The following is a description of a gene set: species: Homo sapiens Mutation or epigenetic silencing of mismatch repair genes, such as MLH1 and MSH2, results in microsatellite instability (MSI) in the genome of a subset of colorectal carcinomas (CRCs). However, little is yet known of genes that directly contribute to tumor formation in such cancers. To characterize MSI-dependent changes in gene expression, we have now compared transcriptomes between fresh CRC specimens positive or negative for MSI (n=10 for each) with the use of high-density oligonucleotide microarrays harboring >44,000 probe sets. Correspondence analysis of the expression patterns of isolated MSI-associated genes revealed that the transcriptome of MSI+ CRCs is clearly distinct from that of MSI- CRCs. Such MSI-associated genes included that for AXIN2, an important component of the WNT signaling pathway. AXIN2 was silenced, apparently as a result of extensive methylation of its promoter region, specifically in MSI+ CRC specimens. Forced expression of AXIN2, either by treatment with 5'-azacytidine or by transfection with AXIN2 cDNA, resulted in rapid cell death in an MSI+ CRC cell line. These data indicate that epigenetic silencing of AXIN2 is specifically associated with carcinogenesis in MSI+ CRCs. Genes down-regulated in colorectal carcinoma samples positive for MSI (microsatellite instability) compared to the MSI negative ones. Human Gene Set: KOINUMA_COLON_CANCER_MSI_DN from publication Koinuma K, Yamashita Y, Liu W, Hatanaka H, Kurashina K, Wada T, Takada S, Kaneda R, Choi YL, Fujiwara SI, Miyakura Y, Nagai H, Mano H (PMID 16247484), and this is the list of marker genes: HSPH1, MLH1, QPRT, EMP1, CHMP4B, PMEPA1, AXIN2, LAPTM4B